The following is a description of a gene set: Human Gene Set: GOBP_POSITIVE_REGULATION_OF_RUFFLE_ASSEMBLY Any process that activates or increases the frequency, rate or extent of ruffle assembly. studied in species Homo sapiens, and this is the list of marker genes: CARMIL2, EPS8L3, DEF8, PLEKHM1, FAM98A (family with sequence similarity 98 member A), EPS8, NDEL1 (NCBI Gene Id 81565), EPS8L2, EPS8L1, NLGN1, COBL, RAC1, PFN1, P2RY12, HRAS